The following is a description of a gene set: from publication Jeffrey KL, Brummer T, Rolph MS, Liu SM, Callejas NA, Grumont RJ, Gillieron C, Mackay F, Grey S, Camps M, Rommel C, Gerondakis SD, Mackay CR (PMID 16474395) species: Homo sapiens Human Gene Set: GSE3982_MEMORY_CD4_TCELL_VS_TH2_DN In the present study we used Affymetrix oligonucleotide microarrays to produce gene transcription profiles for the major leukocyte types in humans. This comprehensive dataset enabled us to not only establish which genes were expressed in each leukocyte type, but also which genes were expressed in each subset after activation. The used of a comprehensive dataset of gene profiles from all the major human leukocyte subsets enabled a novel and powerful means for identification of genes associated with single leukocyte subsets, or different immune paradigms. Genes down-regulated in comparison of memory CD4 T cells versus Th2 cells., and this is the list of marker genes: H4C3, ALDH3A2, ETNK1, MT1H, IER3, GARS1, SLC39A14, MICAL2, FLOT1, TSPAN3, PHKA1, PRMT5, PSMB5, OIP5, COMMD3, PLA2G4A, NASP, EMC8, CCNA2, ARL3, ACOT7, NCBP1, VDR, NTRK1, ADO, SNRPD1, ALDOC, MRPL12, NCAPH, DSG2, RCC1L, LIF, USP22, RMDN1, MCM4, DTL, CCL1, GINS1, EMP1, RNASEH2A, COX17, TRMT5, OSM, POLE2 (DNA polymerase epsilon 2, accessory subunit), PA2G4, RRM1, STK3, CAB39, TRIP13, LARP4, SSRP1, GPN3, TFDP1, MCM6, FH, GTF2A2, MRPL15, AK2, GTF3C5, PPCDC, MYH6, TIE1, CSE1L, BZW1, CSNK2A1, ZWINT, H2AX, RRP7A, CSNK2B, STAP1, RAD51C, SUPT4H1, TIPIN, CDK1, DUSP6, PUM3, CPOX (NCBI Gene Id 201541), ELMO1 (engulfment and cell motility 1), FEN1, RECQL4, SLC16A1, PAPSS1, SERPINE2, ADGRA3, TMEM106C, PSMB2, EIF2S2, CENPU, KIF15, TFB2M, MYH10, SLC25A32, RAB11FIP1, KCTD5, KIF11, MCUR1, MTMR2, PSMD8, PARL, ATG101, FSD1, PHLDA1, CDK2, PSMD14, ENY2, HSP90AB1, XRCC6, IMPDH2, PSMB6, DCTN6, SNAPC1, NDUFS4, PRDX3 (peroxiredoxin 3), XRCC5, ENO1 (NCBI Gene Id 81977), DCTPP1, RHOB, STIP1, ATP9A, VDAC1, GGH (NCBI Gene Id 8836), CKS1B, PBK, PSMD12, SLC16A3, CD200, BLM, IRF4, GRB2 (NCBI Gene Id 80715), ACAT2, MYOF, SQLE, CALML4, PDIA4, NDC80, VDAC2, GMNN, ORC6, HELLS, RBM7, PIP5K1B, AHCY, TTK, PLPP1, FES, EVI5, CA2, RRM2, NUTF2, CTNNA1, INTS13, TPI1, CALU, GALNT2 (NCBI Gene Id 2590), CAPRIN1, MSH2, GINS2, ESF1, MCM2, FILIP1L, PYCR1, YBX3, NUSAP1 (nucleolar and spindle associated protein 1), BLTP3B, CCDC85B, CCT7, GSTT1, HSPE1, VCP, CDCA8, NUDT21, GSTO1, PFDN2, ERCC1, TMEM70, CPSF6, GGCT, SLC7A5, PMCH, PTGS2, MTHFD1, CD38, EGR1, RBM14, CDK7, ABCE1, SCD, PPIF, SEC23B, POLR2K, TOP2A, CKS2, MAD2L1, SMC2, CCT2, NUP37, SDC4, KIF20B, NOP16